The following is a description of a gene set: studied in species Homo sapiens Reactome Pathway: Programmed Cell Death Cell death is a fundamental cellular response that has a crucial role in shaping our bodies during development and in regulating tissue homeostasis by eliminating unwanted cells. There are a number of different forms of cell death, each with a corresponding number of complex subprocesses. The first form of regulated or programmed cell death to be characterized was apoptosis. Evidence has emerged for a number of regulated non-apoptotic cell death pathways, including some with morphological features that were previously attributed to necrosis. Caspase-8 activation tilts the cell towards apoptosis, while caspase-8 inhibition tilts the cell towards Regulated Necrosis.<p>The terminology and molecular definitions of cell death-related events annotated here are consistent with the 2015 recommendations of the Nomenclature Committee on Cell Death (NCCD) (Galluzzi L et al. 2015)., and this is the list of marker genes: DIABLO, CHMP6, HSP90AA1, KPNA1, PRKN, CHMP2B, PSMC6, GZMB, APIP, SEM1, MAPT, PPP3R1, ACIN1, ITCH, H1-2, YWHAE, PSMD11, PSMD1, ADRM1, E2F1, GSDMD, VIM, BIRC3, UNC5B, PSMB3 (proteasome 20S subunit beta 3), STAT3, PSMD8, CHMP7, PPP1R13B, DSG3, OPA1, H1-1, TLR4, H1-5, CTNNB1, DSP, LMNA, DSG2, MAPK1, CHMP4B, RIPK3, YWHAH, TNFRSF10A, DBNL, IRF1, PLEC, PSMD3, ROCK1, GAS2, PSMB2, RPS27A, YWHAZ, ARHGAP10, CASP1, DYNLL1, TJP1 (tight junction protein 1), PRKCD, H1-3, CASP7 (NCBI Gene Id 840), YWHAB, PSMA2, NS, CASP8, TP53, CYCS, IL18, IL1B (NCBI Gene Id 3553), CASP4, BIRC2, ORF71, PSMA4, LY96, PSMD7, CARD8, TP73, UACA, UNC5A, AKT2, AKT3, DCC, TRADD, PSMB7, DYNLL2, APPL1, GSN, IRF2 (NCBI Gene Id 3660), DAPK3, SATB1, PSMD12, CD14, DSG1, DAPK1, HMGB2, C1QBP (complement C1q binding protein), BAD, PSMD2, GSDME, CHMP3, PSMA6, FADD, PSMC5 (NCBI Gene Id 5705), H1-4, TP63, HMGB1, TNFSF10, APAF1, PSMA3, CHMP4C, STUB1, CHMP2A, CASP5, IL1A, PDCD6IP, MC159L, XIAP, TFDP1, UBE2L3, AVEN, SFN, UBA52, PSMC4, CASP9, PPP3CC, DNM1L, CASP3, PSMD13 (NCBI Gene Id 5719), PSMD6, PRKCQ, PSMC2, BID, CFLAR, BBC3, MAPK8, BCL2L1, MLKL, SDCBP, PSMA5, FAS, FLOT1, FNTA, YWHAG, TICAM1, CDH1, UBC, TNFRSF10B, PSMC1, PSMB5, DFFA, AKT1, FASLG, NMT1, OCLN, RIR1, MAGED1, STK24, OGT, UBB, PSMB4, TRAF2, ELANE, CASP6, FLOT2, OMA1, BCL2L11, CDC37, SPTAN1, PTK2, SEPTIN4, STK26, DAPK2 (NCBI Gene Id 23604), BAK1, TFDP2, BMF, PSMA7, PMAIP1, PSMA1, PSMD14, YWHAQ, LMNB1, KPNB1, BMX, PELI1, CHMP4A, BCAP31, PSMC3, BAX, PKP1 (NCBI Gene Id 5317), PAK2, RIPK1, MAPK3, ADD1, DFFB, TP53BP2, CLSPN, PSMB6, H1-0, TICAM2, BCL2, CDKN2A, APC, PSMB1, TJP2